The following is a description of a gene set: Human Gene Set: GOMF_HISTONE_METHYLTRANSFERASE_BINDING Binding to a histone methyltransferase enzyme. studied in species Homo sapiens, and this is the list of marker genes: LCORL, PAXBP1, LCOR, HSP90AB1, PRDM12, PHF1, PRDM14, WIZ, CBX3, ZNF335, PRDM4, RESF1, GATA3, NOP56, CBX1, CTNNB1, PRDM1